The following is a description of a gene set: from publication Amit I, Garber M, Chevrier N, Leite AP, Donner Y, Eisenhaure T, Guttman M, Grenier JK, Li W, Zuk O, Schubert LA, Birditt B, Shay T, Goren A, Zhang X, Smith Z, Deering R, McDonald RC, Cabili M, Bernstein BE, Rinn JL, Meissner A, Root DE, Hacohen N, Regev A (PMID 19729616) mouse primary BMDCs were stimulated with tlr ligands and gene expression changes were profiled on Affymetrix arrays Human Gene Set: GSE17721_CTRL_VS_PAM3CSK4_0.5H_BMDC_DN species: Homo sapiens Genes down-regulated in comparison of control dendritic cells (DC) at 0 h versus those stimulated with Pam3Csk4 (TLR1/2 agonist) at 0.5 h., and this is the list of marker genes: TEC, MRPS15, NEFH, DMC1, ZNRF1, RAG2, PLCL2, LHPP, SF3B4, PAPLN, PPARA, PSMB2, PSMA5, TCAP, STXBP1, PRDX1, ATP5IF1, NIPAL2, DOLPP1, MAST1, BTG3, EHBP1L1, MACROH2A1, PTTG1IP, TOR2A, PAWR, AIRN, CTSG, DDR2, LCE3B, KLHL10, TAB2, GRB7, GPR137B, ANKRD26, STX8, GNAS, RPL14, ALOX15, RPL22, PI4K2A, MMADHC, TM2D3, CELSR2, RWDD4, RDH13, NR2F1 (NCBI Gene Id 7025), CREB3L4 (NCBI Gene Id 338028), PEX14 (NCBI Gene Id 5195), BTC, JPH2, SYP, IAPP, GATAD2B, DYSF, TAC1, LPIN2, STMP1, DNM3, SAP30L, SOBP, TRA2B, RHBDL3, PACC1, PHF5A, AGTRAP, SOAT1, BHLHE41, UBE2R2, ACAA1, ADSS1, RARS2, TRPS1, ZRSR2, COPZ2, KEL, PTPN23, RALGDS, MTMR14, MRPL30, WNT11, WNT2, ABCB4, CDC20, DDX18, PEAR1, PCSK2, LRRC18, LIN7B, DUOXA1, ATP5MC2, THBS3, RBX1, MED11, LHX1, RPL39, MIEN1, TMEM50B, LTBP3, KANSL1L, PTHLH, BRWD1, AKR7A2, PCDHB5, CEMIP, APOA2, ERCC5, MIA2, UTY, ZFAND3, SEMA4G, RHOD, MTERF4, EIF3L, ST3GAL1, IGHM, PPP1R18, CD27, STRN3, LAMA3, ACBD6, LSM1, COX6A2, VAX2, PA2G4, CLIP4, CPA1, AMELX, MRGPRF, PCDHB2, MYO1E, CXCL14, MGAT4C, WFS1, KCNN4, ADAM2, HMMR, ATF7, KLK6, ATP8B3, CAVIN2, MRRF, SMOX, PACS1, MSI1, OGG1, REEP2, MKKS, BRWD3, PLEKHA6, CNNM3, PTGDR, NOL12, HRH3, MED9, ZC3H18, GNA12, VNN1, AUP1, MITF, GDE1, ALDOA, SHC3, SLC26A3 (solute carrier family 26 member 3), FCHO1, DCC, PRSS22, ACSF2, BLOC1S4, ADH5, CTCF, PACRG, FBXW7, PDE6H, MAPK13, KDELR2, ARID5B, CPPED1, IFT81, CAVIN3, HSD3B1, TTC5, HPRT1, BCL11B, UGGT1 (NCBI Gene Id 56886), TEAD2, OLFML3, PYY, ADAMTS8, ADAM33, PRELID1, SPAG7, LGALS1, MPEG1, CD96, HOXD13, DIDO1 (NCBI Gene Id 85362), PHF13, ADIG, MAD2L2